Given this list of marker genes GXYLT1, COL24A1, ARHGAP26, PLPBP, LRP12 (NCBI Gene Id 80002), ETV6, NEURL1, SEC14L4, STOX2, AFF1, CCDC110, SIX4, PSEN1, NFXL1, SHISA7, BRD2, EXOC6B, FADS6, ATP6V1A, FNDC3B, EPM2AIP1, GABARAPL1, UBXN2B, ATP10A, ITM2B, STRN3, EME1, HTR2C, COL1A1, PTPN23, ZNF182, COL5A3, AFG2B, CPB2, UBE2E2, DEGS1, HIPK2 (NCBI Gene Id 653052), TSHR, VAX1, SLC30A8, CDC42BPA, SLC39A11, FTSJ1, ASAP3, AKAP13, ADD3, FSCN1, MYO5A, PAN3, SH3PXD2A, ST8SIA4, FRS2, HTR2B (5-hydroxytryptamine receptor 2B), EIF2AK3, FOSL2, MAPK7, RASGRF2, MAP3K7, DCLK1, MOGS, COMMD2, SELL, PPM1E, ZWILCH, MLLT10, RPP30, MYO6, GLI3, MEDAG, BAG3 (NCBI Gene Id 9531), KAT6A, SYT10, MGP, PHF6, INSYN2A, SINHCAF, SEMA5A, PSME4, HTR3A, DISC1, SMNDC1, CLTRN, ARFGAP3, RBM24, CRELD1, ZNF701, PC, FAM117A, SLC38A2, ERC1, CPD (NCBI Gene Id 1362), TTPA, TET1, HOXA5, ZBTB44, NEK5, SLC16A2, RECQL5, COL25A1 (NCBI Gene Id 84570, collagen type XXV alpha 1 chain), NSD2, IGFBP5, WWC3, ABL2, PTPN4, RAB11FIP1, RND2, NEXMIF, SYNCRIP, DSG1, CBFB, TTPAL, USP24, CLDN22, TP53RK, CHST10, RALBP1, TUB, DENND1B, FGF1, AHCYL1, FGF9, CACHD1, CACNA1A (calcium voltage-gated channel subunit alpha1 A), TRAPPC8, ETV3, ALDH1L2, PGLYRP4, SECISBP2L, SC5D, SRD5A1, VASH1, GOLM1, KIF3B, LRBA, WASF3, TMEM178B, TM2D2, B9D1, DIP2B, GIGYF2, SRSF11, FNDC5, C12orf76, VAPB, KRAS, ZNF583, BAAT, SCUBE2, ITGB8, NPR3, AKAP6, CIR1, MSI2, MEX3C, NFATC1, ABHD17B, SFXN1, GDF10, ABHD14A, GNL3, THRB, UTP18, MAB21L1, TBL1XR1, IL2RA, MRTFB, NECAP1, SYT3, here is a description of the gene set: from publication Chen Y, Wang X (PMID 31504780) Human Gene Set: MIR6088 species: Homo sapiens Genes predicted to be targets of miRBase v22 microRNA hsa-miR-6088 in miRDB v6.0 with MirTarget v4 prediction scores > 80 (high confidence targets).